Given this list of marker genes ATP2A1, MTRF1L, CHRNA3, BTN1A1, MAP3K14 (mitogen-activated protein kinase kinase kinase 14), GABRB1, ZNF154, TEKT2, GPR176, RAB3A, SPAG8, IFNA4, GK2, NPY5R, KCNH1, CD3G, MPHOSPH8, MYH7, ATRNL1, DNASE1L2, TNFSF11, BHMT, OPRPN, CUL3, TCF15, MUC7, KRT37, AP4E1, LRRTM2, ANGPTL7, OPHN1, ZNF208, CHM, VPS41, UGT2B4, SERPINC1, MPPED2, CST5, RPGRIP1L (NCBI Gene Id 23322), HOXD9, CRISP2, MLLT3 (MLLT3 super elongation complex subunit), DMP1, REXO5, FOXN2, CXCL6, SEC14L2, IL18RAP (NCBI Gene Id 8807), IPO8, HCG4, IRGC, DIO1, SLITRK2, SYT11, CBLIF, EPHA7, ZNF264, BAAT, SAA4, RFX1, WNT1, ORC4, BRDT, TBC1D12, ART3, SMYD2, RBM17 (NCBI Gene Id 84991), DOC2A, MYCNOS, HIPK2, AKAP5, AVPR1A, PDE9A, PRORP, FSTL4, NLGN4Y, DSC1, ZNF239, EIF2B1, TBC1D31, KCNA3, RPGRIP1, ASTN1, ODF2, KIT, NTN3, GRM8, LCT, ADAM7, here is a description of the gene set: Human Gene Set: MORF_RAB3A Neighborhood of RAB3A Neighborhood of RAB3A RAB3A, member RAS oncogene family in the MORF expression compendium species: Homo sapiens